Given this list of marker genes EIF4A1, ACTB, ID1, HSP90AB1, SERPINE1, GAPDH, E2F2 (NCBI Gene Id 1870), DUSP5, MIR22HG, here is a description of the gene set: Genes down-regulated in fibroblasts expressing the XP/CS mutant form of ERCC3, after low dose UVC irradiation. species: Homo sapiens from publication da Costa RM, Riou L, Paquola A, Menck CF, Sarasin A (PMID 15608684) Xeroderma pigmentosum (XP) and trichothiodystrophy (TTD) syndromes are characterized by deficiency in nucleotide excision repair pathway, but with distinguished clinical manifestations. While XP patients exhibit a high frequency of skin cancer, TTD patients are not cancer prone. The relation between lack of DNA repair and their clinical manifestations was investigated through analysis of the transcriptional profile of 12,600 transcripts in two isogenic cell lines with different capabilities of DNA repair. These cell lines result from a stable transfection of the XPB-TTD allele into XP complementation group B fibroblasts, from an XP patient who also have clinical abnormalities corresponding to Cockayne's syndrome (CS). The microarray assays performed under normal growth conditions showed the expression of distinct groups of genes in each cell line. The UVC-transcription modulation of these cells revealed the changes in 869 transcripts. Some of these transcripts had similar modulation pattern in both cells, although with eventually different time patterns for induction or repression. However, some different 'UVC signature' for each cell line was also found, that is, transcripts that were specifically UV regulated depending on the DNA repair status of the cell. These results provide a detailed portrait of expression profiles that may potentially unravel the causes of the different phenotypes of XP/CS and TTD patients. Human Gene Set: DACOSTA_LOW_DOSE_UV_RESPONSE_VIA_ERCC3_XPCS_DN